Given this list of marker genes Lck, Stat5a, Ptk2b, Il2rg, Syk (NCBI Gene Id 20963), Stat5b, Il2ra, Il2rb (NCBI Gene Id 16185), Shc1, Il2, here is a description of the gene set: studied in species Mus musculus Interleukin-2 signaling Mouse Gene Set: REACTOME_INTERLEUKIN_2_SIGNALING